Given this list of marker genes Prf1, Prdx2, Rbms3, Rela, Spi1, Laptm5, Plk5 (NCBI Gene Id 216166), Klf4, Dlec1, Dapk1, Abi3, here is a description of the gene set: Reactions triggered in response to the presence of a tumor cell that act to protect the cell or organism. Mouse Gene Set: GOBP_DEFENSE_RESPONSE_TO_TUMOR_CELL species: Mus musculus